The following is a description of a gene set: Genes down-regulated in head and neck tumor samples which clustered around known hypoxia genes. Affymetrix U133plus2 GeneChips were used to profile 59 head and neck squamous cell cancers. A hypoxia metagene was obtained by analysis of genes whose in vivo expression clustered with the expression of 10 well-known hypoxia-regulated genes (e.g., CA9, GLUT1, and VEGF). To minimize random aggregation, strongly correlated up-regulated genes appearing in >50% of clusters defined a signature comprising genes, of which 27% were previously known to be hypoxia associated. The median RNA expression of the genes in the signature was an independent prognostic factor for recurrence-free survival in a publicly available head and neck cancer data set, outdoing the original intrinsic classifier. In a published breast cancer series, the hypoxia signature was a significant prognostic factor for overall survival independent of clinicopathologic risk factors and a trained profile. The work highlights the validity and potential of using data from analysis of in vitro stress pathways for deriving a biological metagene/gene signature in vivo. from publication Winter SC, Buffa FM, Silva P, Miller C, Valentine HR, Turley H, Shah KA, Cox GJ, Corbridge RJ, Homer JJ, Musgrove B, Slevin N, Sloan P, Price P, West CM, Harris AL (PMID 17409455) species: Homo sapiens Human Gene Set: WINTER_HYPOXIA_DN, and this is the list of marker genes: CHPT1, CD79A, ZSCAN18, NCKAP1L, GYPC, DOCK2, HLA-DOB, FRZB, CD28, PBXIP1, BCL2, SYNE1, IL16, KLHDC1, RIPOR2, ENPP2, ITM2A, ICAM2, EVI2A, IKZF1, ATP8A1, ARHGAP45, ABCB1, GIMAP7, IRAG2, ITGB2-AS1, ATP8B1-AS1, PTPRC, ANKRD44, ATM, ISCU (NCBI Gene Id 91850), SYNPO2, CCL19, ARHGAP15, SLC25A20, TLR7, SYNRG, INPP5D, IRF8, FLI1, RGS5, ARHGEF6, CD48, CELF2, GIMAP1, ARL6IP5, RUBCNL, LMO2, EVI2B, PARM1, FBLN5, RESF1